The following is a description of a gene set: Human Gene Set: TRAVAGLINI_LUNG_BRONCHIAL_VESSEL_1_CELL studied in species Homo sapiens from publication Travaglini KJ, Nabhan AN, Penland L, Sinha R, Gillich A, Sit RV, Chang S, Conley SD, Mori Y, Seita J, Berry GJ, Shrager JB, Metzger RJ, Kuo CS, Neff N, Weissman IL, Quake SR, Krasnow MA (PMID 33208946), and this is the list of marker genes: TSPAN13, ADGRL4, IFITM1, NPM1, ACTN1, RPL35A, PTMA, RPS24, ZFAS1, RPL34, MCTP1, PTMS, COTL1, BACE2, RPS6, ADAMTS1, RPL8, ANP32B, OLFM1, GAS5, RPL24 (ribosomal protein L24), MTHFD2 (NCBI Gene Id 10797), GADD45A (NCBI Gene Id 1647), NUAK1, RPL31, RPS13, SOCS3, ENO1 (enolase 1), UGCG, EHD4, HMGN1, NOP16, CMIP, POLE4, NNMT, APOLD1, CDC37, IMPDH2, RPL38, EGR3, ENPP2, DIPK2B, RPL5, RPS14, TMEM70, RUNDC3B, VWA1, PKP4, RPL29, RPL22L1, RPL23A, SWAP70, LDHA, RPL35, RPL22, ANGPT2, INHBB, RPL4, RSL1D1, MGLL, RPS15A, IGFBP7, PABPC1, GASK1B, RPS15, RPS2 (ribosomal protein S2), UBA52, HBEGF, RPL21, ADM5, HSPG2 (heparan sulfate proteoglycan 2), TAGLN, LGALS3, LAPTM4B, PRDX4, PLVAP, CCDC85B, RPL19, CDA, FOXC1, HSPE1, LITAF, RPSA2, RPS27A, EIF3F, EIF4B, RPL13, RPL18, RBP7, CCDC3, PFDN5 (NCBI Gene Id 5204, prefoldin subunit 5), RPS23, ZFAND5, RPS12, BHLHE40, PRDX6, SPRY1, RPL15, GNL3, EPS8, PITPNC1, MAT2A, ZNF385D (NCBI Gene Id 79750), SEMA6B, RPL26 (NCBI Gene Id 6154), LYRM1, RPS20, ETS2 (ETS proto-oncogene 2, transcription factor), RPL39, RPS3A, PNP, MLEC, PPP3CA, RPS19, ACKR1, ABCB1, FAU, NR4A2, EVL, RPS16, NET1, CYYR1, RPS27, IGFBP2, PCDH17, RCAN1, HAPLN3, MYC, RPL30, DDX21 (NCBI Gene Id 9188), RPL18A, RPL37, INSR, RPL10A, SNHG16, UXT, SERBP1, TESC, RPLP1, RPL10, RPLP2, RPL23, UPP1, RPS5, RPS7 (ribosomal protein S7), CCN1, CDKN1A (NCBI Gene Id 1026), NME1, RPLP0, PFKP, C11orf96, NDRG1, RPL12, RPSA, SNRPD1, NHP2, ARID5A, RPS28, HSP90AB1, RPL36, PIM1, MYL9, EIF3E, RPL6, CMAHP, RPS3, ITPKC, DUSP23, RPL37A, RPL13AP5, GJA1, RPL7, FOXO1, BZW2, RELL1, MPZL2, CCN2, ZFP36L2, SLC25A5 (solute carrier family 25 member 5), RPL27, PALMD, MEF2C, RPL41, THBS1, RPS8, C2CD4B, SPARCL1, HNRNPA1, EGR1, TPT1, RPL28, NACA, SNRPE, ARID5B (AT-rich interaction domain 5B), EGR2, EIF3G (eukaryotic translation initiation factor 3 subunit G), FAM43A, SPP1, COL15A1, RPL32, ADAMTS4, CDC42EP3, RPL27A, RSL24D1, RPS29, RPL11, RDX, NCOA7, RPS4X, RPL14 (ribosomal protein L14), TM4SF18, HSPD1, FAM110D, MGP, EIF3D, RPL3, RPL13A, CPXM2, ADAMTS9, TRIB1, UQCRB, EEF2, RPS21, POSTN (periostin)